Given this list of marker genes Hpf1 (NCBI Gene Id 72612), Xrcc1, Tinf2, Pnkp, Banf1, Spindoc, Pum3, Kat2b, here is a description of the gene set: Any process that modulates the frequency, rate or extent of protein ADP-ribosylation. Protein ADP-ribosylation is the transfer, from NAD, of ADP-ribose to protein amino acids. Mouse Gene Set: GOBP_REGULATION_OF_PROTEIN_ADP_RIBOSYLATION species: Mus musculus